Given this list of marker genes ITGB3BP, YAP1, RPA1, UGT2B28, SASH1, HLA-DQB1, CA2, CDYL, PAPPA, KDR, NANOS1, A2M, FAM241A, IGFBP5, HLA-DRB5, NLGN1, CA5A, FIRRM, RNFT1, MLH3, MAGOHB, ENSG00000285976, ZNF367, DPYSL3, IGF2, IFT70A, BTLA, KRT5, MAP3K7CL, RGS18, SPC25, APCDD1L, HLA-DQA1 (NCBI Gene Id 7946), HLA-DOA, ENTREP2, IRF8, TNS1, CABLES1, BET1, TGFBI, FAM83D, HLA-DRA, NRN1, CAAP1, TMEM70, MYEOV, CAVIN2, ZNF490, ERV3-1, LYSMD3, TC2N, MACROD2, EPAS1, HSD17B3, LILRA4 (leukocyte immunoglobulin like receptor A4), ENKUR, GPR88 (NCBI Gene Id 54112), MFAP3L, PHEX, SLC4A8, ZNF438, COL4A1, RNF212B, ZNF117, PID1, SH2D1A, STRBP, KIF26A, KRTAP29-1, COL25A1, CAVIN1, DCK, CCDC50, VWA8 (NCBI Gene Id 23078), ALG1L2, TAS2R14, LPL, PLD4, NXT2, ATP13A5, SYNPO, COL4A2, PLCL1, ANKDD1B, H2BC7, H2AC13, CPAMD8, CLIC5, ZNF660, LGALS2, MECOM, MAPK10, CEMIP, CTNND2, ZNF347, IL3RA, LEPR, ST8SIA6, PF4V1, ENTHD1, SETD7, PHACTR3, H4C9, AGBL3, STK26, SLC18A3, PACSIN1, DLK1, TNFRSF21, FLNB, PLCB1, WNT9A, TTPAL, P2RY10, AVPR1A, SPIB, POLR3G, HEMGN, H2AC15, ALDH1A1, MS4A7, PDCD1LG2, P2RY12, UTRN, DYTN, PRIMPOL, TGFB2, SEPTIN10, SLFN14, ACKR2, STXBP6, MSANTD3-TMEFF1, TNFSF18 (TNF superfamily member 18), H2BC13, ARHGAP29, ADAM12, CD34, RAMP3, ALDH1A2, TFPI2, SMIM36, ENAH, DENND11, KCND3, DNAH12, FTO, SCIN (NCBI Gene Id 85477), TBX3 (NCBI Gene Id 91834), WLS, REG1B, CXCL5, EFNA5, IL7R (interleukin 7 receptor), NOMO1, CEP128, H2BC9, BACH2, TECTA, MEX3B, here is a description of the gene set: Strongly downregualted genes from differential gene expression analysis of platelets from 4 ICU patients with SARS-CoV-2 infection as well as 5 healthy donors. studied in species Homo sapiens Thrombotic complications in patients with COVID-19 are common and contribute to organ failure and mortality. Patients with severe COVID-19 present with hemostatic abnormalities that mimic disseminated intravascular coagulopathy associated with sepsis with the major difference being increased risk of thrombosis rather than bleeding. However, whether SARS-CoV-2 infection alters platelet function to contribute to the pathophysiology of COVID-19 remains unknown. In this study, we report altered platelet gene expression and functional responses in patients infected with SARS-CoV-2. from publication Manne BK, Denorme F, Middleton EA, Portier I, Rowley JW, Stubben C, Petrey AC, Tolley ND, Guo L, Cody M, Weyrich AS, Yost CC, Rondina MT, Campbell RA (PMID 32573711) Human Gene Set: MANNE_COVID19_ICU_VS_HEALTHY_DONOR_PLATELETS_DN